The following is a description of a gene set: Human Gene Set: LI_WILMS_TUMOR_ANAPLASTIC_DN studied in species Homo sapiens Selected down-regulated genes distinguishing between Wilms tumors of different histological types: anaplastic vs favorable histology. Anaplasia (unfavorable histology) is associated with therapy resistance and poor prognosis of Wilms tumor, but the molecular basis for this phenotype is unclear. Here, we used a cDNA array with 9240 clones relevant to cancer biology and/or kidney development to examine the expression profiles of 54 Wilms tumors, five normal kidneys and fetal kidney. By linking genes differentially expressed between fetal kidney and Wilms tumors to kidney morphogenesis, we found that genes expressed at a higher level in Wilms tumors tend to be expressed more in uninduced metanephrogenic mesenchyme or blastema than in their differentiated structures. Conversely, genes expressed at a lower level in Wilms tumors tend to be expressed less in uninduced metanephrogenic mesenchyme or blastema. We also identified 97 clones representing 76 Unigenes or unclustered ESTs that clearly separate anaplastic Wilms tumors from tumors with favorable histology. Genes in this set provide insight into the nature of the abnormal nuclear morphology of anaplastic tumors and may facilitate identification of molecular targets to improve their responsiveness to treatment. from publication Li W, Kessler P, Williams BR (PMID 15531917), and this is the list of marker genes: TACC1, RBBP6, IFI16, STAT4, CASP10